Given this list of marker genes Apip, Casp9, Aven, Cycs, Mapk3, here is a description of the gene set: studied in species Mus musculus electronically inferred by orthology from the curated human pathway Reactome Pathway: Regulation of the apoptosome activity This event has been computationally inferred from an event that has been demonstrated in another species.<p>The inference is based on the homology mapping from PANTHER. Briefly, reactions for which all involved PhysicalEntities (in input, output and catalyst) have a mapped orthologue/paralogue (for complexes at least 75% of components must have a mapping) are inferred to the other species. part of: Formation of apoptosome